Given this list of marker genes CBL, RAB2A, C1orf21, DYRK3, DBT, RICTOR, SRSF6, BLCAP, LARP4, RB1, FAM229B, MECP2, ADGRL3, DDX3X, MTMR4, ALCAM, LRRFIP1, TCF7, NIPBL, KLHL42 (NCBI Gene Id 57542), AQP4-AS1, H3-3B, NRIP1, PCDH19, FNDC3B, PKP4, ARHGAP36, TMTC3, BHLHE22, ACVR2A, WDR44, PPP1R3D, B4GALT2, CCNT2, GRHL1, ILRUN, ZEB2, OLIG3, DYRK1A, LPAR4, ZNF536, MSN, ARFGEF1, MIPOL1, CTNNBIP1, RABGAP1, DDX6, here is a description of the gene set: species: Homo sapiens Genes having at least one occurence of the motif TAGGTCA in their 3' untranslated region. The motif represents putative target (that is, seed match) of human mature miRNAs hsa-miR-192 and hsa-miR-215 (v7.1 miRBase). Human Gene Set: TAGGTCA_MIR192_MIR215